The following is a description of a gene set: The gene expression program underlying the specification of human cell types is of fundamental interest. The study authors generated human cell atlases of gene expression and chromatin accessibility in fetal tissues. For gene expression, the study authors applied three-level combinatorial indexing to >110 samples representing 15 organs, ultimately profiling ~4 million single cells. The study authors leveraged the literature and other atlases to identify and annotate hundreds of cell types and subtypes, both within and across tissues. Our analyses focused on organ-specific specializations of broadly distributed cell types (such as blood, endothelial, and epithelial), sites of fetal erythropoiesis (which notably included the adrenal gland), and integration with mouse developmental atlases (such as conserved specification of blood cells). These data represent a rich resource for the exploration of in vivo human gene expression in diverse tissues and cell types. studied in species Homo sapiens Human Gene Set: DESCARTES_FETAL_HEART_MEGAKARYOCYTES Marker genes curated from the annotated cluster as represented in the Descartes Human Gene Expression During Development database. from publication Cao J, O'Day DR, Pliner HA, Kingsley PD, Deng M, Daza RM, Zager MA, Aldinger KA, Blecher-Gonen R, Zhang F, Spielmann M, Palis J, Doherty D, Steemers FJ, Glass IA, Trapnell C, Shendure J (PMID 33184181), and this is the list of marker genes: GP5, DCLRE1A, HGD, ALOX12, PF4, EREG, GATA1, PSTPIP2, TSPAN32 (NCBI Gene Id 10077), RHAG, BEND2, ENTHD1, TMEM72, ABCB11, SRC, SLC37A1, LINC02752, LIPH, LCN2, P2RX1, LY6G6F-LY6G6D, RCCD1-AS1, ZNF778, FERMT3, MPIG6B, KCNK17, CXCL5, GP1BA, HEMGN, TNFRSF14-AS1, NFE2 (nuclear factor, erythroid 2), ENSG00000233968, MFSD2B, H2BC11, TUBA8 (tubulin alpha 8), PTH2R, INHBA-AS1, TUBA4A, ACRBP, NEXN-AS1, TAL1, RAB27B, EFCAB13-DT, TMEM91, PIRAT1, MYO3B, SYTL4, RUFY1, CMTM2, CISH, ITGA2B, TUBB1, H2AC6, TPSAB1, LINC01140, AQP10, PADI4, MPL, CXCR2P1, HPSE, RPS3AP34, H2BC5 (NCBI Gene Id 3017), MDM1, GFI1B, EGF, VWA5A (von Willebrand factor A domain containing 5A), PPBP, LYL1, LEFTY1, PRKAR2B-AS1, RHD, MPP1, CNST, XK, SLC2A3, TPSB2, PLEK, CLEC1B, ADCYAP1, NRGN, GP9, TRIM58, LINC02506, NT5C3A (NCBI Gene Id 96002), MED12L, ELOVL7, HBD, SLC35D3, SPATA16, ENSG00000255367, F2RL3, GP6, KIT, SERPINE1, THBS1, CPA3, PTCRA, TREML1, TNFSF4, SMIM24, LY6G6F, RGS18, LGALSL, ITGB3, CA2 (NCBI Gene Id 760), MFAP3L, PAQR5, ABCC3, LINC00534, H2BC12, LINC02284